Given this list of marker genes AKR1C4, AKR1D1, AKR1C2, AKR1C3, AKR1C1, here is a description of the gene set: species: Homo sapiens Human Gene Set: GOMF_KETOSTEROID_MONOOXYGENASE_ACTIVITY Catalysis of the reaction: O2 + NADPH + progesterone = H2O + NADP+ + testosterone acetate.